Given this list of marker genes ALB, BICDL1, PTK2B, RGS6, PTK7, COL6A2, SMARCD2, VEGFD, LCN2, IFNAR2, NPIPB3, CD38, AJAP1, NFATC3, COL6A1, KRT37, BTF3P12, IFI27, ST8SIA3, ASPA, SOCS3, EGR2, APBA2, CAV3, CAMK2G, HSF2BP, COL2A1, PDYN, GC, MIR9-1HG, TFEC, DUSP1, RHOB, ZFP36, GPX3, JUNB, CTNNA2, ADH1A, DCTN5, PLXDC1, POT1, FAM13A, EYA4, EGR3, KITLG, FOS, TSFM, CBARP, TSPY2, SIX6, APOM, THBS1, ZER1, C4BPB, here is a description of the gene set: Genes up-regulated in primary fibroblast cell culture at 30 min time point after infection with HCMV (AD169 strain). Human Gene Set: BROWNE_HCMV_INFECTION_30MIN_UP from publication Browne EP, Wing B, Coleman D, Shenk T (PMID 11711622) species: Homo sapiens The effect of human cytomegalovirus (HCMV) infection on cellular mRNA accumulation was analyzed by gene chip technology. During a 48-h time course after infection of human diploid fibroblasts, 1,425 cellular mRNAs were found to be up-regulated or down-regulated by threefold or greater in at least two consecutive time points. Several classes of genes were prominently affected, including interferon response genes, cell cycle regulators, apoptosis regulators, inflammatory pathway genes, and immune regulators. The number of mRNAs that were up-regulated or down-regulated were roughly equal over the complete time course. However, for the first 8 h after infection, the number of up-regulated mRNAs was significantly less than the number of down-regulated mRNAs. By analyzing the mRNA expression profile of cells infected in the presence of cycloheximide, it was found that a minimum of 25 mRNAs were modulated by HCMV in the absence of protein synthesis. These included mRNAs encoded by a small number of interferon-responsive genes, as well as beta interferon itself. Cellular mRNA levels in cytomegalovirus-infected cells were compared to the levels in cells infected with UV-inactivated virus. The inactivated virus caused the up-regulation of a much greater number of mRNAs, many of which encoded proteins with antiviral roles, such as interferon-responsive genes and proinflammatory cytokines. These data argue that one or more newly synthesized viral gene products block the induction of antiviral pathways that are triggered by HCMV binding and entry.